The following is a description of a gene set: The chemical reactions and pathways resulting in the breakdown of a leukotriene, a pharmacologically active substance derived from a polyunsaturated fatty acid, such as arachidonic acid. species: Mus musculus Mouse Gene Set: GOBP_LEUKOTRIENE_CATABOLIC_PROCESS, and this is the list of marker genes: Dpep1, Cyp4f14, Cyp4f18, Cyp4f40, Cyp4f15, Dpep2, Cyp4f13